Given this list of marker genes Clec4d, Batf, Irf4, Il10, Batf2, Tgfb1, Cd37, Tnfsf9, Traf6, Cd244a, Tgfbr2, Klrk1, Batf3, Stard7, Gimap5, Tspan32, Pycard, Havcr2, Gimap3, Csf2, Hmgb1, Itgb6, Spi1, Pirb, Ltbr, Ubd, Psen1, Rbpj, Notch2, Itgb8, Il4, Camk4, Dcstamp, Dock2, Pilrb1, Relb, Flt3l, Slamf1, here is a description of the gene set: The change in morphology and behavior of a dendritic cell resulting from exposure to a cytokine, chemokine, cellular ligand, or soluble factor. Mouse Gene Set: GOBP_MYELOID_DENDRITIC_CELL_ACTIVATION species: Mus musculus